Given this list of marker genes FTL, SOX4, HP, RIPK1, EEF2, TNNI3, APP, F12, IFNAR2, ATP1A1, PDIA4, CTSZ, ALOX5AP, RARS1, FKBP3, AP1B1, CACNB3, SSC4D, SLC6A13, STARD10, SLC6A8, STAT3, HSPB8, VDAC1, EFS, RABAC1, PPP2R1A, FABP1, PCYT1A, SERPING1, ATP5F1D, MYH9, CD81, GCLM, PDIA3, CAPNS1, AZGP1, SERPINC1 (serpin family C member 1), FDX1 (NCBI Gene Id 2230), G3BP2, FZD4 (NCBI Gene Id 8322), PEA15, MYL2, SARS1, CP, EIF3B, APOB, PPP1CA, SCN1B, EEF1A1, CYP7A1, EIF2S2, VWF, CD151, ACTB, MGAT1 (alpha-1,3-mannosyl-glycoprotein 2-beta-N-acetylglucosaminyltransferase), HPN, MAN2A1, NFIA, RRAS, CFH, JUP, EIF5A, AKR1C4, CD36, DDB1, TSPAN4, ZFP36L1, ATP6V0C, ACTN4, SORD, PRPSAP1, EIF4G3, SOX17, GNB2, MAP2K2, DYNC1H1, GALK1, YWHAQ, LONP1, UBC, here is a description of the gene set: Down-regulated in hepatocytes upon expression of NOS2. Nitric oxide (NO) can modulate numerous genes directly; however, some genes may be modulated only in the presence of the inflammatory stimuli that increase the expression of the inducible nitric oxide synthase (iNOS). One method by which to examine changes in NO-mediated gene expression is to carry out a gene array analysis on NO-nai;ve cells. Herein, we report a gene array analysis on mRNA from iNOS-null (iNOS(-/-)) mouse hepatocytes harvested from mice exposed to NO by infection with an adenovirus expressing human iNOS (Ad-iNOS). Of the genes on this array, only approximately 200 were modulated either up or down by the increased iNOS activity according to our criteria for significance. Several clearly defined families of genes were modulated, including genes coding for proinflammatory transcription factors, cytokines, cytokine receptors, proteins associated with cell proliferation and cellular energetics, as well as proteins involved in apoptosis. Our results suggest that iNOS has a generally anti-inflammatory and anti-apoptotic role in hepatocytes but also acts to suppress proliferation and protein synthesis. The expression of iNOS results in increased expression of stress-related proteins, including heme oxygenase-1 (HO-1). We used HO-1 to confirm that a significant change identified by an analysis could be demonstrated as significant in cells and tissues. The elevation of HO-1 was confirmed at the protein level in hepatocytes in vitro. Furthermore, iNOS(-/-) mice experienced greatly increased liver injury subsequent to intestinal ischemia/reperfusion injury, associated with an inability to upregulate HO-1. This is the first study to address the global gene changes induced by iNOS in any cell type, and the findings presented herein may have clinical relevance for conditions such as septic or hemorrhagic shock in which hepatocytes, NO, and HO-1 play a crucial role. Human Gene Set: ZAMORA_NOS2_TARGETS_DN from publication Zamora R, Vodovotz Y, Aulak KS, Kim PK, Kane JM 3rd, Alarcon L, Stuehr DJ, Billiar TR (PMID 12381414) studied in species Mus musculus